Given this list of marker genes ELAPOR1, TMPRSS3, ADD3, CENPS, SFXN2, BATF, DNAJC22, BMP7, HOXC6, CCDC121, HADH, TST, MIPEP, SLC16A6, MST1R, S100A16, SNHG7, MYO10, HOMER3, GALC, SLC1A4, IL11, TRMT5, HAUS4, ANXA9, TSPAN1, SLC12A2-DT, BCAR3, SP100, LONRF2, MEAK7, RECQL4, PKIA, RHNO1, C10orf95, ITGB5 (integrin subunit beta 5), FIGNL1, CYSTM1, TFPI, ABHD12, PMAIP1, LGR4, CAV2, FXYD3, CUTALP, RGS16, ZXDC, PARM1, RHOF, LATS2, TMEM30A, SYK, PREX1, GUCY1A1, PTGES, RCC1, MOB3C, ANXA2, LRCH4, TET1, ST20-AS1, MYO1E, FAM234B, DUBR, KLF6, DHFR, EZR, DRAM1, HLA-B, YIPF6, STC2, CTNND2, SMTN, CFLAR, RBM4B, SLC12A6 (solute carrier family 12 member 6), CA8, TSC22D2, JAG1, PIK3R1, NR2F2, EZH2 (NCBI Gene Id 392834), ZFAND5, RBM3, BCL2L11, NT5E, PCNT, RBM12B, PBX1, LCORL, LEPR, ITPK1, C9orf72, MBNL2, ANKRD11, PRLR (prolactin receptor), SOX2, LHFPL6, ITGA3, TMTC4, PPP1R18, ITCH, ASPM, WWTR1, SLC4A7, KCTD5, CEP68, RMI1, CDC7, SH3RF1, LINC01116 (NCBI Gene Id 375295), NET1, WWOX, ENTPD3, KLHL5, PXMP2, ANGPTL4, ACSS3, NDUFS1, MAFK, LMNB1, SRSF1, ZNF689, MYOF, TGFA, CHN1, AP1S3, FBP1, SYNE2, PHLDB2, RAB3B, IGF2BP2, XBP1, RPS6KA5, RASSF8, GALNT10, DLGAP4, C6orf141, SHB, EPB41L4A-AS1, DUT (NCBI Gene Id 1854), MTHFD1, CD55, KIF15, STAT1, RAPGEF6, SAPCD2, OSR2, ZNF362, NUP133, DAAM1, H4C3, LRP10, NPNT, EDEM1, MBOAT2, PROCR, CAVIN1, CDKN1A, KATNBL1, CDC45, TMEM150C, ZNF185, KISS1, CCDC71L, SDCBP2, PRIM1, ITGA5 (integrin subunit alpha 5), GPX3, GLIS3, PDLIM7, TYMS, SDC2, PPP2R3A, PLXND1, SAP30L, RMND1, HMGN5, ERO1A, ARRB1, COL13A1, IER5, RAP2C, HIRIP3, MYDGF, ADAM9, LOXL2, SNHG5, PGAP6, TMPO, DNM3, EHD1, GALNT2, ACTN1, PHF14, MTUS1, RFXAP, CLIC3, IL1R2, CLDN1, FAM117B, TOM1L2, OXCT1, TP53, HOXC9, PXDN, FANCD2, TBC1D9, NAP1L1, AKR7A2, SKA3, ABTB3, ZNF165, RIIAD1, THYN1, ST8SIA4, CRNDE, CUL4A, RPRM, SQOR, GEN1, HILPDA, CD59, GNA14 (G protein subunit alpha 14), SLC35A1, SMYD3, FSTL3, HLA-A, TMEM156, E2F7, B3GNT5, TSPAN3, ENSG00000284634, ZNF233, FBXO4, PLAUR, IFT70B, TNFRSF10A, H1-10, ETS2, SYTL1, MTERF2, MGLL, MIS18A, GPD1L (NCBI Gene Id 23171), PDE3B, EFHD1, STC1, PXN (NCBI Gene Id 80229), JADE1, LDLR, E2F8, SH3BP5, DSCAM, LIAT1, IDS, LDLRAD4, PARPBP, CYP4B1, P4HA2, LRIG1, TPD52L1, ISG20, DRAIC, PCP4, FAM110B, GABBR2 (gamma-aminobutyric acid type B receptor subunit 2), CD44, MICA, HK2, ALDH5A1, CLTB, SPOCD1, CEP128, CA12, ANKRD22, AIF1L, LMO4, LRCH3, AKAP13 (A-kinase anchoring protein 13), HSPB8, PLA2G4C, CACNA1D, GINS2, MMP1, SFXN3 (NCBI Gene Id 94083, sideroflexin 3), TFF3, SLC35F2, SNHG32, CENPM, CCDC34, RERG, TCEA2, ARL4A, H2AZ2, APPL1, POLA1, H2AC11, PRR15, SUSD1 (sushi domain containing 1), SRCAP, SPRED1, SNX27, ITGB6, SH3BGRL3, ALDH1A3, ALDH3B2, ECI1, H2AC8, SMURF1, ESR1, DYNC2I2, GPX8, RPL5, SAP30, B4GALT4, RNASEH2A, RIT1, DLEU2, FAM43A, PPP1R3C, FAM201A, LAMC1, IL15RA, TJP3, TOMM34, DZIP3 (NCBI Gene Id 9666), HPCAL1, FAM89A, MTARC1, BCL2A1, CTTN, KALRN, SGCG, EPHA1, H2AX, MAPRE3, MET, PTCH1, MTARC2, CENPN, SIX1, ID2, PMEPA1, RAB39B, STEAP1, GLCCI1, TMSB15B, DSG2, S100A2, FNDC3B, LYST, MCCC2, CENPV, ABCG2, GPC1, SH3BGRL, BRCA2, MCM4, HMGN3, NR5A2, WDR26, COA1, GPR68, RAD51AP1, RBMX, PRKCA, ERCC1, ERMARD, CMBL, IL13RA1, PLOD2, CYP2J2, PSIP1 (NCBI Gene Id 93428), CENPU, DTYMK, CTNNAL1, C3orf52, DSC2, BMAL2, KIF3C, MICB, UBE2E3, NCAPG, EPS8L1, CLEC2D, CREB3L4, TAB3, SH2D3A, VEGFC, KIF11, FXYD5, MNS1, ITGB1, KLHL2, VDR, FAM131B, IFT122, here is a description of the gene set: Human Gene Set: PEDERSEN_METASTASIS_BY_ERBB2_ISOFORM_7 species: Homo sapiens from publication Pedersen K, Angelini PD, Laos S, Bach-Faig A, Cunningham MP, Ferrer-Ramón C, Luque-García A, García-Castillo J, Parra-Palau JL, Scaltriti M, Ramón y Cajal S, Baselga J, Arribas J (PMID 19364815) HER2 is a tyrosine kinase receptor causally involved in cancer. A subgroup of breast cancer patients with particularly poor clinical outcomes expresses a heterogeneous collection of HER2 carboxy-terminal fragments (CTFs). However, since the CTFs lack the extracellular domain that drives dimerization and subsequent activation of full-length HER2, they are in principle expected to be inactive. Here we show that at low expression levels one of these fragments, 611-CTF, activated multiple signaling pathways because of its unanticipated ability to constitutively homodimerize. A transcriptomic analysis revealed that 611-CTF specifically controlled the expression of genes that we found to be correlated with poor prognosis in breast cancer. Among the 611-CTF-regulated genes were several that have previously been linked to metastasis, including those for MET, EPHA2, matrix metalloproteinase 1, interleukin 11, angiopoietin-like 4, and different integrins. It is thought that transgenic mice overexpressing HER2 in the mammary glands develop tumors only after acquisition of activating mutations in the transgene. In contrast, we show that expression of 611-CTF led to development of aggressive and invasive mammary tumors without the need for mutations. These results demonstrate that 611-CTF is a potent oncogene capable of promoting mammary tumor progression and metastasis. Genes regulated in MCF7 cells (breast cancer) by expression of the truncated (611-CTF) form of ERBB2 at 60 h time point.